The following is a description of a gene set: studied in species Mus musculus Mouse Gene Set: GOMF_PROMOTER_SPECIFIC_CHROMATIN_BINDING Binding to a section of chromatin that is associated with gene promoter sequences of DNA., and this is the list of marker genes: Hdac1, Zfp750, Hdac2, Trp53, Sox10, Ercc4, Suz12, Prdm15, Wdr13, Pcgf2, Gtf2f1, Foxo4, Nr3c1, Taf5, Nfe2l1 (NCBI Gene Id 18023), Runx1, Ndn, Ep300, Stat1, Atf2, Ddx5, Zc3h4, Sirt1, Foxc2, Ikzf3, Irf3, Rbl1, Kat8, Ercc1, Pparg, Ehmt2, Atf4, Ercc3, Gli2, Zfp683, Klf4, Fos, Trim33, Polr2a, Trp63, Mecp2, Nup98, Gadd45a, Pdx1, Foxo1, E2f4, L3mbtl2 (L3MBTL2 polycomb repressive complex 1 subunit), Setdb1 (NCBI Gene Id 99808), Foxc1, Pcgf1, Bmi1, Taf10, Nipbl, Usp3, Chd7, Esr1, Med1, Kdm1a, Isl1, Ppargc1a, Esr2, Ezh2, Dnmt1, Smad3, Nrl, Hnrnpu, Pou4f2, Trim28, Dhx9, Zfp609, Gtf2b, Egr1, Hsf1, Taf1, Hdac4, Prdm1 (NCBI Gene Id 12142), Mybl1, Tcf7l2, Fosl1 (fos-like antigen 1), Myod1, Macroh2a1, Hnf1b, Rbl2